The following is a description of a gene set: Mouse Gene Set: GOCC_DENDRITIC_BRANCH studied in species Mus musculus A dendrite arising from another dendrite., and this is the list of marker genes: Marcks, Map1a, Dlg4, Akap9, Grin1, Map2, Grin2b